The following is a description of a gene set: species: Homo sapiens Apoptosis triggered by inadequate or inappropriate adherence to substrate e.g. after disruption of the interactions between normal epithelial cells and the extracellular matrix. Human Gene Set: GOBP_ANOIKIS, and this is the list of marker genes: ANKRD13C (NCBI Gene Id 81573), MAP3K7, NOTCH1, SRC, ITGB1, TSC2, PIK3CA, MTOR, BMF, NTRK2 (neurotrophic receptor tyrosine kinase 2), PTRH2, PTK2, BRMS1, BCL2L1, TLE1, CEACAM6, ITGA5, CAV1, PDK4 (pyruvate dehydrogenase kinase 4), BCL2, MYBBP1A, TLE5, DAPK2, E2F1, CRYBA1, IKBKG, ZNF304, STK11, SNAI2, TFDP1, CEACAM5, AKT1, MCL1, PIK3R3, SIK1, CHEK2